The following is a description of a gene set: An impairment of the ability to track objects with the ocular smooth pursuit system, a class of rather slow eye movements that minimizes retinal target motion. studied in species Homo sapiens Impaired smooth pursuit Human Gene Set: HP_IMPAIRED_SMOOTH_PURSUIT, and this is the list of marker genes: ITPR1, ENSG00000288330, SACS, POLR3B (NCBI Gene Id 55703), PLA2G6, TSEN54, ATXN2, TULP1, MAN2B1, STXBP1, DPM2, PAFAH1B1, ATXN10, FGF14, TBCD, PEX10, STT3A, TMEM216, INPP5E, KCND3, NOP56, XRCC4, ATXN8OS, SYT14, RARS1, ATXN1, THG1L, EEF2, FTL, RFC1, ATXN3, SYNE1, PDHB, CACNA1A, PRNP, SPTBN2, MRE11, ZFHX3, WARS2, GNB1, KCNN2, ELOVL4